Given this list of marker genes Kif5a, Rab17, Hpca (hippocalcin), Ada, Kif3b, Kcnab1, Uhmk1, Map2k1, Kif21b, Hip1r, Map2k4, Sod1, Grik3, Cdkl5, Wls, Mapk8, Stau2, Gria2, Mapk1, Abhd13, Klhl17, Camk2a, Kif3a, Kif5c, Flot2, Kif17, Zc3h14, Lrrk2, Map2, Canx, Abhd12, Kifap3, Grik2, Baiap2, Dlg4, Oprm1, Gabarapl1, here is a description of the gene set: species: Mus musculus Mouse Gene Set: GOCC_DENDRITE_CYTOPLASM All of the contents of a dendrite, excluding the surrounding plasma membrane.